Given this list of marker genes ACSF2, SLC27A4, ACSL1, SLC27A3 (solute carrier family 27 member 3), SLC27A6, ACSBG1, SLC27A5 (NCBI Gene Id 22942), ACSBG2, ACSM1, SLC27A2, ACSL6, SLC27A1, ACSL5, ACSL4, ACSL3, here is a description of the gene set: Catalysis of the reaction: a long-chain fatty acid + ATP + CoA = a long-chain fatty acyl-CoA + AMP + diphosphate. A long-chain fatty acid has an aliphatic tail containing 13 to 22 carbons. species: Homo sapiens Human Gene Set: GOMF_LONG_CHAIN_FATTY_ACID_COA_LIGASE_ACTIVITY